Given this list of marker genes MED12L, DHX30, FRMD4A, SLC29A3, KAT6A, RIN2, here is a description of the gene set: Upper eyelid edema Edema in the region of the upper eyelid. Human Gene Set: HP_UPPER_EYELID_EDEMA studied in species Homo sapiens